Given this list of marker genes ALDH2, DCPS, MRPS6, PCGF6, NUP58, NANP, LSM14A, NAA30, FAM216A, MAIP1, ZNF146, ZBTB45, TIMM29, MCFD2, CANX, KLF10, SGPL1, HOOK2, SNX1, UFD1, FAM117B, ZBTB14, RRP36, TIMM10, SURF6, PTTG1IP, GOSR2, PIK3IP1, SARS2, PGAM5, PRKRIP1, AHR, PRXL2A, GMCL1, UFM1, PFDN5, LIG4, HMGB3, IER3IP1, TNPO3, RBM48, NIPSNAP3A (NCBI Gene Id 93242), XRN2, TRMT6, C1orf122, SPTSSA, GFER, TERF2IP, GUCY1B1, CACNB3, UBE2D2, GTF3C4, CD164, TXNL4B, THAP11, KLHL7, RAD1, TOR3A, FIP1L1, BID, CD34, TAB2, CHGB, C4orf46, DDX28, MACIR, ATG12, FKBPL, MED14, PITHD1, HAUS2, EFL1, PNO1, NEU3, RPLP0, OLA1, RDX, CTU1, MBP, SELENOI, PARP16, DNAAF10 (NCBI Gene Id 116143), CCDC171, PDGFD, SAP30BP, RNF114, UTP6, DR1, COA5, GLE1, RUNDC3B, PSME2, RBPJ, ZSWIM1, KPNA4, IER5, YAF2, RPS4X, FAM199X, PRKRA, TIFA, ADAM9 (NCBI Gene Id 8754), ZNF777 (zinc finger protein 777), TRIAP1, FAM133B, MRPL45, HASPIN, HILPDA, RPL22, MZT1, MRPS15, RABL3, H2BC13, RPRD2, GNAI3, RIPOR2 (RHO family interacting cell polarization regulator 2), COIL, EMC6, TSGA10, UBR7, PPWD1, RCAN1, CCDC32, DDX27, YBX1, PPRC1, MRPS27, ZBTB44, PDZD11, TIMM22, EID1, ZDHHC20, PDRG1, TMX4, PAPSS1, SLC36A4, YY1, KNSTRN, SEPTIN10, TFAM, B2M, DPAGT1 (NCBI Gene Id 1799), PPIL4, UTP4, ABCE1 (NCBI Gene Id 6059), ZBTB26, RAG1, TUBG1, SLC16A1, HDAC2, NHLRC2, VCPIP1, DPF2, MRM2, RAB9A, TRIM23, PSRC1, RPS9, UEVLD, NOP16, CCT8, NKAP, CPSF2, FAM168B, NATD1, GYG1, WDR82, MRPL44, TARS1, RMND5A, TRIP4, ANKRD46, ASNSD1, IWS1, PDHX, TP53INP1, BPNT2, MRPL9, RNPEP, TSHZ1, GGPS1, TSEN34, AHCYL2, ERP29, WDR76, TRIM59 (NCBI Gene Id 353185), VPS4A, FGFR1OP2, COX15, CHCHD1, EIF4H, MRPL49, CS, TENT5C, SMAD4, ZBTB8A, TMED7, AKIRIN1, POLR2F, CLCN3, here is a description of the gene set: Human Gene Set: GSE16385_MONOCYTE_VS_12H_ROSIGLITAZONE_TREATED_MACROPHAGE_DN studied in species Homo sapiens Genes down-regulated in monocytes (12h) versus macrophages (12h) treated with rosiglitazone. Human CD14 positive monocytes were purified from healthy volunteers’ blood and cultured in vitro for 4, 12, 24, 72 hours. While culturing, macrophages were activated alternatively with interleukin-4 (IL-4 100 ng/ml) or classically with interferon-gamma (IFNg 100 ng/ml)+tumor necrosis factor (TNF 50 ng/ml) or left without activation. Simultaneously, macrophages were also treated with vehicle (DMSO:ethanol) or 1mM synthetic PPARg agonist, Rosiglitazone. We used Affymetrix microarrays (U133Plus 2.0) to analyze activation and PPARg-induced gene expression changes. from publication Szanto A, Balint BL, Nagy ZS, Barta E, Dezso B, Pap A, Szeles L, Poliska S, Oros M, Evans RM, Barak Y, Schwabe J, Nagy L (PMID 21093321)